Given this list of marker genes NEIL1, IL12A, CRHBP, RAD54B, CS, MAN1B1, ADGRB1, FOXP3, CEBPG, TAPT1 (NCBI Gene Id 202018), DLG4, POLL, ELOVL7, RAD51B, STAG3, REC8, PARP2, GSTM3, here is a description of the gene set: species: Homo sapiens Genes down-regulated in peripheral blood mononuclear cell 28d vs 3d in adults (50-74) (in common with both HAI and VNA) after exposure to Fluarix, time point 28D, administered i.m.. Comment: Common Genesets with genes entering regression models for HAI and VNA Responses, withlog2 Day 28 vs Day 3 fold-change in gene expression as the explanatory variables Human Gene Set: OVSYANNIKOVA_PBMC_FLUARIX_AGE_50_74YO_COMMON_WITH_BOTH_HAI_AND_VNA_28DY_VS_3DY_USED_IN_HAI_AND_VNA_RESPONSE_MODELS_DN This study aimed to identify gene expression markers shared between both influenza hemagglutination inhibition (HAI) and virus-neutralization antibody (VNA) responses. We enrolled 158 older subjects who received the 2010-2011 trivalent inactivated influenza vaccine. Influenza-specific HAI and VNA titers and mRNA-sequencing were performed using blood samples obtained at Days 0, 3 and 28 post vaccination. For antibody response at Day 28 versus Day 0, several gene sets were identified as significant in predictive models for HAI (n=7) and VNA (n=35) responses. Five gene sets (comprising the genes MAZ, TTF, GSTM, RABGGTA, SMS, CA, IFNG and DOPEY) were in common for both HAI and VNA. For response at Day 28 versus Day 3, many gene sets were identified in predictive models for HAI (n=13) and VNA (n=41). Ten gene sets (comprising biologically related genes, such as MAN1B1, POLL, CEBPG, FOXP3, IL12A, TLR3, TLR7 and others) were shared between HAI and VNA. These identified gene sets demonstrated a high degree of network interactions and likelihood for functional relationships. Influenza-specific HAI and VNA responses demonstrated a remarkable degree of similarity. Although unique gene set signatures were identified for each humoral outcome, several gene sets were determined to be in common with both HAI and VNA response to influenza vaccine. from publication Ovsyannikova IG, Salk HM, Kennedy RB, Haralambieva IH, Zimmermann MT, Grill DE, Oberg AL, Poland GA (PMID 27534615)